The following is a description of a gene set: Human Gene Set: WP_ZINC_HOMEOSTASIS Zinc homeostasis studied in species Homo sapiens, and this is the list of marker genes: SLC39A6, SLC39A12, SLC30A5, SLC30A10, SLC39A8, SLC30A6, SLC39A7, SLC30A8, MT1A, MT2A, SLC39A4, SLC30A3, SLC39A10, SLC30A9, MT1L, MTF1, SLC30A2, MT4, MT3 (metallothionein 3), SLC39A1, SLC30A7 (NCBI Gene Id 148867), MT1E, SLC39A2, MT1F, SLC39A9, MT1X, SLC30A4, SLC39A3, MT1B, SLC39A13 (NCBI Gene Id 91252), SLC39A11, MT1H, SLC39A14, SLC30A1, MT1M, SLC39A5, MT1G